Given this list of marker genes RPS27A, UBE2D2, DERL1, RRAGA, PAF1, RNF40, CTR9, H2BC15, H2BC12 (H2B clustered histone 12), H2BC14, HLTF, HLA-B (NCBI Gene Id 730410), H2BC5, H2BC4, SHPRH, UBE2A, SELENOS, VCP, H2BC1, H2BC9, UBE2D3, UBE2E1, UBE2D1, RAD18, RTF1, PEX5, PCNA, RNF181, RNF152, H2BC17, UBE2N, PRKDC, H2BC11, UBE2L3, RNF144A (ring finger protein 144A), SKIC8, PEX14, US11, CDC73, PEX2 (peroxisomal biogenesis factor 2), UBB, TMEM129, RNF20, H2BC13, UBE2J2, PEX10, PEX13, UBE2V2 (NCBI Gene Id 7336), LEO1, UBA52, HLA-A, UBC, BCL10, WAC, PEX12, H2BC3, UBE2B, here is a description of the gene set: studied in species Homo sapiens part of: Protein ubiquitination Reactome Pathway: E3 ubiquitin ligases ubiquitinate target proteins E3 ubiquitin ligases catalyze the transfer of an ubiquitin from an E2-ubiquitin conjugate to a target protein. Generally, ubiquitin is transferred via formation of an amide bond to a particular lysine residue of the target protein, but ubiquitylation of cysteine, serine and threonine residues in a few targeted proteins has also been demonstrated. Based on protein homologies, families of E3 ubiquitin ligases have been identified that include RING-type ligases, HECT-type ligases, and RBR-type ligases. A subset of the RING-type ligases participate in CULLIN-RING ligase complexes (CRLs which include SCF complexes, reviewed in Lee and Zhou 2007, Genschik et al. 2013, Skaar et al. 2013, Lee et al. 2014).<br>Some E3-E2 combinations catalyze mono-ubiquitination of the target protein. Other E3-E2 combinations catalyze conjugation of further ubiquitin monomers to the initial ubiquitin, forming polyubiquitin chains. (It may also be possible for some E3-E2 combinations to preassemble polyubiquitin and transfer it as a unit to the target protein.) Ubiquitin contains several lysine (K) residues and a free alpha amino group to which further ubiquitin can be conjugated. Thus different types of polyubiquitin are possible: K11 linked polyubiquitin is observed in endoplasmic reticulum-associated degradation (ERAD), K29 linked polyubiquitin is observed in lysosomal degradation, K48 linked polyubiquitin directs target proteins to the proteasome for degradation, whereas K63 linked polyubiquitin generally acts as a scaffold to recruit other proteins in several cellular processes, notably DNA repair.